Given this list of marker genes Hsp90b1, Stat6, Il2rg, Stat3, Jak2, Il4, Socs1, Tyk2, Il4ra, Il13ra1, Il13 (NCBI Gene Id 16163), Socs5, Il13ra2, here is a description of the gene set: Interleukin-4 and Interleukin-13 signaling Mouse Gene Set: REACTOME_INTERLEUKIN_4_AND_INTERLEUKIN_13_SIGNALING studied in species Mus musculus